The following is a description of a gene set: Reactome Pathway: Hemostasis Hemostasis is a physiological response that culminates in the arrest of bleeding from an injured vessel. Under normal conditions the vascular endothelium supports vasodilation, inhibits platelet adhesion and activation, suppresses coagulation, enhances fibrin cleavage and is anti-inflammatory in character. Under acute vascular trauma, vasoconstrictor mechanisms predominate and the endothelium becomes prothrombotic, procoagulatory and proinflammatory in nature. This is achieved by a reduction of endothelial dilating agents: adenosine, NO and prostacyclin; and by the direct action of ADP, serotonin and thromboxane on vascular smooth muscle cells to elicit their contraction. The chief trigger for the change in endothelial function that leads to the formation of a haemostatic thrombus is the loss of the endothelial cell barrier between blood and extracellular matrix components. Circulating platelets identify and discriminate areas of endothelial lesions; here, they adhere to the exposed sub endothelium. Their interaction with the various thrombogenic substrates and locally generated or released agonists results in platelet activation. This process is described as possessing two stages, firstly, adhesion - the initial tethering to a surface, and secondly aggregation - the platelet-platelet cohesion (Savage & Cattaneo et al. 2001). Three mechansism contribute to the loss of blood following vessel injury. The vessel constricts, reducing the loss of blood. Platelets adhere to the site of injury, become activated and aggregate with fibrinogen into a soft plug that limits blood loss, a process termed primary hemostasis. Proteins and small molecules are released from granules by activated platelets, stimulating the plug formation process. Fibrinogen from plasma forms bridges between activated platelets. These events initiate the clotting cascade (secondary hemostasis). Negatively-charged phospholipids exposed at the site of injury and on activated platelets interact with tissue factor, leading to a cascade of reactions that culminates with the formation of an insoluble fibrin clot. studied in species Homo sapiens, and this is the list of marker genes: ANGPT2, IGHV3-48, ITGA1 (integrin subunit alpha 1), IGKV2D-40, OLA1, GATA2, SERPINA1, SELE, FLNA, DOCK4, GNGT2, PRKCH, CDK5, IGLV2-11, GNB4, IGKV1-39, DOCK10, WDR1, KIF18A, RHOG, ANO6, P2RX5, ITGB2, GYPA, CYRIB (CYFIP related Rac1 interactor B), PSG3, MICAL1, GNG3, PAFAH2, TUBAL3, THBD, IGHV, IGKV1-17, PTPN11, CAV1, CD99L2, F8, GNB5, AKAP10, NOS3, POTEKP, KIF22, GNA11, PCYOX1L, GP1BA (NCBI Gene Id 2811), GATA4, CDC37L1, IGLC3, PTGIR, DOCK3, CEACAM1, GATA3, eba-140, ATP1B3, RAPGEF3, FYN, IGLC6, PPBP, TUBB8, MAPK3, DGKE, TLN1, PIK3CB, SPN, A1BG, ATP2A1, F11, ITGA2B, DOCK9, opaF, IGLV3-1, CABLES2, ABHD6, TMX3, IGKV1-33, DAGLA, IGLV3-12, opaE, SLC8A2, MAFF, IGLV3-19, PPP2CA, STX4, DOCK6, PRKCD, opaH, ECM1, CD109, GUCY1A2, H3-3A, CEACAM3, MAFG, LEFTY2, KIF23, GPC1, LHFPL2, PPIL2, HSPA5 (heat shock protein family A (Hsp70) member 5), TTN, KIF3B (NCBI Gene Id 9371), FAM3C, PDE10A, CEACAM5, KIF11, IGKV1-16, PPP2R5D, IGF2 (insulin like growth factor 2), CD47, ITGAX, GNAI1, ADRA2A, GNB3, CD99, CD63, SRGN, EHD3, PDGFA, KIF3A, HBD, F9, IGLV4-60, NFE2, TUBA8, opaJ, CYB5R1, ARRB2, RAB27B, CFL1, TUBA1A, ITGAV (integrin subunit alpha V), IGLV, APLP2, TNFRSF10B, ITPR1, IGLV2-8, TSPAN7, ITGA6, IGHV3-30, SERPINA5, PIK3R2, PLAU, INPP5D, eba1, GTPBP2, TRPC3, IGHV1-46, H3C15, ANXA5, AKT1, VCL, IFNA6, IGKC, KCNMB1, ACTN2, KIF19, ITGA5, ITGAM, IGKV1D-33, IGKV3D-20, YES1, PPP2R1B, IFNA8, P2RX4, PFN1, KIF21B, PRKG2, KIF9, PRKCQ, ITGA4, MMRN1, RASGRP2, KIF26B, ORM1, STXBP2, IFNA10, STIM1, PSG9, P2RX6, GPC3, PTK2 (NCBI Gene Id 5747), PLCG2, IGKV1D-16, MANF, HBB, MIF, IGHA2, GNA14, FCER1G, CD9, KIF28P, P2RY1, LRP8, SERPINA10, TUBB1, KIF15, IFNA2, PLEK, KLC2, SLC8A3, BCAR1, SHC1, HMG20B, GP9, CTSW, KIF6, PPP2R5E, IGLV3-16, PROZ, PDGFB, IFNA13, GNG10, CD58, ABL1, GATA1, ZFPM2, IFNA17 (interferon alpha 17), MAPK1, KLKB1, P2RX7, PPP2CB, PROS1, SDC4, RAP1B, DGKZ, KIF13B, IGLL1, opaD, SH2B3, KIF25, A2M, piiC, KCNMB3, S100A10, RAC1, IGLV1-51, MFN1, IGLV1-47, IGKV1-12, DGKK, PSG6, KIF26A, GNB1, BSG, SIRPA, KNG1, ACTB, GNG7, VEGFD (NCBI Gene Id 2277), CD74, F10, opaG, SLC7A10, RAD51C, AHSG, KIF2A, PLCG1, PRKACG, PICK1 (NCBI Gene Id 9463), TUBB4A, P2RY12, SELENOP (selenoprotein P), WEE1, IGHV3-53, KIF4B, KIF5B, SERPINA3, ABHD12, GLG1, GNG5, KLC4, IGKV4-1, PRKG1, GNAQ, KCNMA1, SLC7A8, CENPE, IFNA1, JCHAIN, PDE2A, KCNMB2, VTI1B, ATP2B1, SPARC, PSG4, CABLES1, PRKAR2A, IGLV3-25, SOS1, DAGLB, SYK, IGKV1D-12, RAPGEF4, VEGFB, TUBB3, VPREB1, SPP2, HRAS, VPS45, IGF1, CLEC1B, HGF (NCBI Gene Id 317720), TUBB8B, TUBB2B, PSG2, opaC, KIF1A, IGLV1-44, CALU, SLC7A11, NHLRC2, TBXA2R, RAF1, KIF3C, SERPINE2, VPREB3, GUCY1B2, KIF4A (NCBI Gene Id 55595), KLC3, IGLV2-14, AGRN, CHID1, IGKV5-2, IGLV4-3, F13B, RCOR1, PPP2R1A, ITPK1, MFN2, ALB, SMPD1, GNA13, RAD51B, APP, HRG, HDAC1, IRAG1, TUBA1C, ACTN4, AKAP1, GRB7, PTPN6, IGKV3-15 (NCBI Gene Id 28913), SRC, TNFRSF10D, ORM2, FCAMR, VEGFC, IGLV1-36, F2RL3, TEX264, RASGRP1, IFNA4, PDPK1, PRKAR2B, IGHV4-59, AK3, IGHV2-5, SERPING1, KIFAP3, YWHAZ, BRPF3, LGALS3BP, ITPR2, SELL, ISLR, PIK3R1 (NCBI Gene Id 5295), RBSN, CAPZA1, GNA12, FERMT3, CD36 (NCBI Gene Id 948), DOCK11, ESAM, ATP2B2, PSG11, FGB, IGLV6-57, TMSB4X, DGKD, CD244, IGLV7-43, IGHV3-9, COL1A2, KDM1A, IGKV2-30, F5, PPP2R5A, ZFPM1, IFNA7, P2RX3, ENDOD1, GPC4, PRTN3, KIFC1, GP5, RACGAP1, SIRPG, CDK2, IGHV3-7, GUCY1A1, TP53, MPL, ORAI2, MAGED2, GYPC, SERPINB2, CBX5, HBE1, PIK3R3, L1CAM, IGHV3-33, CRK, LYN, IGKV2D-28, IFNB1, TRPC6, F12, IFNA5, F13A1, CD2, IGHV3-11, ADRA2C, IGHV4-39, GPC5, IFNA14, CAP1, KCNMB4, KRAS, EPCAM, CEACAM8, opaB, CLU, F2, IGKV2-29, ITGA2, PCDH7, ANGPT1, IGHA1, TOR4A, IGKV3-11, IGHV1-69, TUBB4B, P2RX1, PRKCE, IGKV3-20, SYTL4, SH2B2, F3, IGLV2-23, opaA, KIF12, ITGB1, ITGA10, NOS2, HABP4, PPIA, RAP1A, ORAI1, F7, RAC2, F2RL2, PLA2G4A, VAV3, OLR1, JAM2, GNG4, ATP2A2, PLG, GPC6, GP6, HDAC2, DGKB, SELP, APOH, KIF16B, IGHV3-23, SERPINB6, SH2B1, CD84, IRF1, IGLV2-33, SERPIND1, EHD2, IGLV3-21, PLAT, IGHV7-81, CDC42, PRKCZ, DGKH, PRKCG, CLEC3B, P2RX2, ATP2B4, SLC16A1, CEACAM6, ATP1B2, SERPINC1, GATA5, SERPINF2, TUBA4B, GNG12, ITIH3, PPP2R5B, TUBA3C, TUBA3D, H3C1, JMJD1C, PPP2R5C, GNAI3, MGLL, FGG, PRKCB, LY6G6F, GATA6, SDC1, PDE1B, GYPB, ITGB3, LAMP2 (NCBI Gene Id 3920), IGLV2-18, MAG, APBB1IP, THPO, PRKCA, GNB2, ITGAL, KIF18B, IGLV3-27, CD177, SLC3A2, PSG5, KIF21A, GRB14, FN1, SLC16A8, opaK, SERPINB8, IFNA16, IGKV1D-39, PDE9A, GPC2, KIF5C, IGLV4-69, IRF2, LAT, IGLV10-54, PLAUR, GNG2, IGLV7-46, TUBA3E, CD44, IGLC2, MAFK, SDC3, PHACTR2, NOS1, IGHV3-13, SRI, HSPG2, GAS6, KIF1C, PIK3CG, KIF20A, LCP2, IGKV1-5, IFNA21, EHD1, TGFB1, IGLV11-55, RARRES2, IGHM, KLC1, IGKV2-28, ATP2B3, ITIH4, GNG13, PIK3R5, SLC8A1, DOCK7, MPIG6B, ATP2A3, ADRA2B, IGLC1, GNGT1, PSG7, PF4V1, MYB, DOCK5, TIMP3, SIN3A (NCBI Gene Id 25942), PSAP (NCBI Gene Id 83009), VEGFA, VAV2, MAPK14 (mitogen-activated protein kinase 14), PHF21A, DOCK8, IGLV5-37, IGLV5-45, QSOX1 (NCBI Gene Id 5768), COL1A1, SLC7A5, KIF2C, PTPN1, PDE1A, CXADR, CALM1, SLC16A3, IGLC7 (NCBI Gene Id 28834), DOCK2, CAPZB, DGKI (NCBI Gene Id 9162), FGR, JAM3, IGHV4-34, SCG3, TEK, KIF2B, CAPZA2, IGKV2D-30, CFD, VWF, KIF27, TREM1, GRB2, F11R, ITGA3, ANO5, ADAMTS13, LCK, RHOB, CD48, SERPINA4, PRKAR1B, SCCPDH, PRKAR1A, TUBB6, ATP1B1, PDPN (NCBI Gene Id 29912), GNG11, SERPINE1, APOA1, SOD1, KIF1B, GNAT3, ABCC4, PDE5A, STXBP3, DGKG, ANGPT4, IGLV1-40, SDC2, RAB5A, APOOL, PECAM1, FGA, RHOA, HBG1, NRAS, opaI, PSG8, TUBB2A, DOK2 (NCBI Gene Id 9046), MMP1 (matrix metallopeptidase 1), GNA15, ebl-1, TRPC7, EGF, CSK, IGHV1-2, IGLV3-22, TAGLN2, MERTK, PF4, JAK2, F2R, KIF5A, TNFRSF10A, TIMP1, TUBA4A (tubulin alpha 4a), PROCR, TGFB3, TFPI, TUBA1B, DGKA, GUCY1B1, ITPR3, SLC7A6, GP1BB, ANXA2, KIFC2, CARMIL1, PRKACB, DOCK1, TGFB2, ALDOA, GNAI2 (NCBI Gene Id 2771), ARRB1, IGLV8-61, DGKQ, PSG1, APOB (NCBI Gene Id 338), SLC7A9, JAML, GNAS, SELPLG, PIK3CA, TF, GNG8, VAV1, KIF20B, PIK3R6, SLC7A7, ACTN1, PROC, IGHV2-70, THBS1, AAMP, PRKACA, HBG2, PDE11A